Given this list of marker genes ADCYAP1, RASSF3, MFNG, DOK6, FHIP1B, STRBP, CERT1, LEF1 (NCBI Gene Id 51176), FAM210B, KBTBD8, RPRD2, ABHD13, FAM199X, ISL1, S100PBP, EFNB2 (ephrin B2), FBXO30, HAS3 (NCBI Gene Id 3038), THRB, FBXO3, TNRC18, ZNF398, CCNA2, KCNH8, FURIN, ELMOD2, GRAMD1B, CGNL1, CAMK1D, ZNF697, GXYLT1, CDH1, PPARGC1A, BICRAL, SDK1, ABRAXAS1, ARHGAP26 (Rho GTPase activating protein 26), ATG14, TBXT (T-box transcription factor T), PIGG, CC2D1A, CLASP1, NR2C2, LGALSL, SLC12A8, ELOVL7, ERG, SOX14, PDE4D, AKAP6, ADGRE2, KCNA4, MIER3, PRG4, SNRK, FBXO42, PIGR (NCBI Gene Id 5284), SLC39A10, RIMS1, WEE1, SYT5 (synaptotagmin 5), ROR1, TPCN1, LURAP1L, IL5RA, SLC35E1, TRHDE, ANAPC10, ARMC8, UBR1, EYA2, AKAP13, INPP5J, SLC31A1 (solute carrier family 31 member 1), UBASH3B, SLK, DIAPH3, SLC16A7, CAPS, CDYL2, PDGFRA, PARD3, LAPTM4A, RAB35, SSBP2, SKIDA1, ANKRD52, CHD7, ZNF704, SEMA4G, FOXJ3, CNRIP1, PRKAA2, SH3D19, TGFBR2, CD164, RBMS3, TMX4 (thioredoxin related transmembrane protein 4), ZBTB18, SLC41A1, ZEB2, ZNF561, TSC22D2, UBE3A, CXXC5, PRDM16, KIAA1549, SLC46A3, TSPAN2 (NCBI Gene Id 10100), MMS19, ANKRD44, ABCB10, SOX6, CHRNA3, DCBLD2, DNAJC6, LPP, SCAI, UBE2Z, PCDH17, CXXC4, ASH1L, CLOCK, DAZAP1 (NCBI Gene Id 26528), COL9A1, RBM24, OCRL, IL12B, MEF2D (myocyte enhancer factor 2D), IFT70A, TENM2, STK38L, ZC3H6, CCDC28A, GREB1, PPDPFL, MBNL1, RECK, DCAF10, CRLF3, THSD7B, DDAH1, LSAMP, MRTFA, ETV5, EYA1, BTBD7, DNAL1, MECOM (MDS1 and EVI1 complex locus), TMEM98 (transmembrane protein 98), here is a description of the gene set: from publication Chen Y, Wang X (PMID 31504780) species: Homo sapiens Genes predicted to be targets of miRBase v22 microRNA hsa-miR-4782-3p in miRDB v6.0 with MirTarget v4 prediction scores > 80 (high confidence targets). Human Gene Set: MIR4782_3P